The following is a description of a gene set: Human Gene Set: GOBP_TISSUE_MIGRATION The process in which the population of cells that make up a tissue undergo directed movement. species: Homo sapiens, and this is the list of marker genes: HIF1A, ZEB2, TACR1, RTN4, SASH1, ADIPOR1, FGF10, FERMT1, TACSTD2, VIL1 (NCBI Gene Id 7429), PTPRG (protein tyrosine phosphatase receptor type G), HDAC6, PTK2, CORO1A, WDPCP, MIR130A, PKN1, PFN1, RAB11A, ARF6, FGF7, MAP4K4, IFNG, MMP9, PKN2, GRHL2, OCLN, KIT, FGF8, PLCG2, MIR379, CLASP1, GDF6, ROCK1, HBEGF, MCC, PPARD, PLCG1, MIR222, MTOR, PTPRR, RREB1, ARHGAP5, CTSH, ADAM9 (NCBI Gene Id 8754), MAPRE2, EPB41L5, ACTC1, ACTA1, PTPN23, HAS2 (NCBI Gene Id 3037), PROX1, MACIR, MACF1, IL4, LRG1, JUN, SNAI1, IQSEC1, DOCK5, DUSP10, CAPN7, DAB2IP, MARVELD3, SOX9, PRKCE, WNT5A, EPB41L4B, TAC1, TGFB2, PFN2, LTB4R2, CD63, DAAM2, KANK1, EPPK1, BMPR2, CLASP2, TESK1, KRT16, EVL, DOCK1 (dedicator of cytokinesis 1), RAB25, APELA, MIR221, NANOS1 (NCBI Gene Id 340719), SMAD4, KANK2, PKN3, FOXF1, IRS2, ANLN, KRT2, PTEN, PTPN11, ACTG2 (actin gamma 2, smooth muscle), ARSB, SRC, ENPP2, CORO1C, ITGA3, KITLG, TGFBR2, SNAI2, INSL3, ACTA2, PPM1F, FAT2, ITGA2, GLIPR2